The following is a description of a gene set: Mouse Gene Set: GOBP_RELAXATION_OF_CARDIAC_MUSCLE The process in which the extent of cardiac muscle contraction is reduced. species: Mus musculus, and this is the list of marker genes: Gsn, Camk2g, Pik3ca, Atp1b1, Hrc, Pde4d, Ttn, Chga, Kcnj2, Akap6, Rgs2, Atp2a2, P2rx4, Pde5a, Camk2d (calcium/calmodulin-dependent protein kinase II, delta)